Given this list of marker genes SPINT1, GJA1, RASSF7, EDIL3-DT, TNNT1, CDH3, CA9, DPP6, HAS1, ABI3BP, CARNS1, PALLD, CDH20, RALYL, KRT7, PROCR, MGAM, KLK11, INHBA, STK31, COL9A3, MGP, GSDME, FAHD2B, LSAMP, NETO1, LINC02613, MPP2, TGFB3, ZBTB7C, SMPD3, MYO5B, GSTM3, SFRP5, SMTNL2, DNAH7, COL8A2, CNGB3, MEIS1-AS3, BOC, EIF2AK3-DT, PTGFRN, OGN, CNTN3, PPM1E, NTNG1, LONRF2, FRMD6-AS2, NXNL2, BASP1-AS1, ALDH1A2, ITGB4, LRRIQ1, STON1-GTF2A1L, PDPN, PRX, ZBTB47, PHLDA3, PRDM6, ZNF649, PLAAT5, TFPI2, MUC16, PLCE1, TPBG, LINC00922, B4GALNT4, NBL1, SLC34A2, TTLL9, LAMA5 (laminin subunit alpha 5), LOX, CDH22, KRT18, SEMA3C, PIANP, FREM2, PAPPA, ADGRB2, HS6ST3, CASC20, LINC02643, LINC01996, SAMD11, COL11A1, COL12A1, GAS6, NXPH2, DLGAP2, CFAP221, GOLGA2P7, PLLP, C6orf132, GRIN2A, MYADM-AS2, MDGA1, TTC23L, EFNA4, CYP2W1, EGR1, IGSF9, ANKRD13B, GSG1L, LINC01508 (long intergenic non-protein coding RNA 1508), ARHGAP44, ARHGEF4, LINC01031, SULF1, TMSB15A, AMIGO1, CLIC3 (NCBI Gene Id 9022), CTNNA3, PTPRD, GFPT2, PHF21B (NCBI Gene Id 50609, PHD finger protein 21B), ODAD3, EPCIP, TEKT5, SPOCK1, TAF1A-AS1, KNDC1, FZD7, CYSTM1 (NCBI Gene Id 84418), ELN, MGAT4C, AXIN2, MMP24, RYR2, PDE7B, COL4A6, SMOC2, LRRN1, TENM3, PIWIL4-AS1, LINC01331, RTL8A, LRRTM3, PRR15-DT, LHX9, FLRT3, CFAP46, MIR100HG, CSDC2, HSPB2, ATF3, SLIT3, PTPRQ, OSR1, GALNT9, ELFN1, FBN3, IL17RE, PNMA8A, GRID2, GRIK2, SNAP91, SLC8A2, TLL1, CRB2, GNGT1, NEK5, LINC01140, PPL, MAD2L1BP, ACOXL, ARFGEF3, FGF18, TMEM132B, FOXC1, FNDC1, DISP1, RAB34, PDGFRL, GAS1, PARM1, COL21A1, ADAMTS9-AS1, LINC02381, ID4, VIT, RBFOX1, THSD4, EFEMP1, KRT19, EMP2, ARHGEF26, EPHB6, ALOX15, LURAP1L, RASSF8 (NCBI Gene Id 11228), ERBB4 (NCBI Gene Id 2066), PDLIM4, ADTRP, LGALS3, CAVIN1, CRIP1, CRACDL, ENTPD2, POF1B, FLNC, S100A10, HSPA1B, EZR, TMEM132C, LAMA3, CA11, FGF9, NKD1, MTMR7, LINC03051, DDR1, PDZK1IP1, HCFC1R1, CRYAB, NPNT, EPHA6, JPH4, WT1, WT1-AS, KLF2-DT, EVPL, SEMA3B, EPS8L1, POU6F2, CLIC5, NEBL, BNC2, GPC4, ASAH1-AS1, ITGB8, MAP3K21, SPEG, MEOX2, TRABD2B, CPAMD8, DPP4, NTRK3, RRAD, CFAP54, GADL1, KCNJ15, HTRA1, PNMA2, GRIA4, GABRB2, RGMA, CNGA4, MEDAG, NCR3LG1, SLPI, GRIN3A, PTPRF, PLA2G2A, PODXL (NCBI Gene Id 5420), C1QTNF1, CCDC80, AOX1, ADAMTS15, SILC1, PTPRT, COL4A3, ARL4D, CBX8, FAM110C, MYRF, SLITRK4, CYP4X1, LINC02024, UPK3B, LY6H, PTPRU, SEZ6L2, FXYD7, DSC3, CFTR, KLF5, SLC4A4 (solute carrier family 4 member 4), DCT, GXYLT2, VSTM2A, CTXN1, MSLN, TMEM132A, SPOCK2, SLC16A1, LAMC2, CFAP299, ABCG4 (ATP binding cassette subfamily G member 4), BNC1, CBLN2, CAVIN3, CGN, PEX5L (peroxisomal biogenesis factor 5 like), TGM1, C1QL1, NPHS1, SDR42E1 (short chain dehydrogenase/reductase family 42E, member 1), BRINP2, IGFBP5, PRR36, RSPO1, RHPN2, LMO4, CSPG5, KCTD8, COL8A1, ITGA3, CDON, HS3ST5, DNAI7, WNT2B, LRP2, here is a description of the gene set: species: Homo sapiens The gene expression program underlying the specification of human cell types is of fundamental interest. The study authors generated human cell atlases of gene expression and chromatin accessibility in fetal tissues. For gene expression, the study authors applied three-level combinatorial indexing to >110 samples representing 15 organs, ultimately profiling ~4 million single cells. The study authors leveraged the literature and other atlases to identify and annotate hundreds of cell types and subtypes, both within and across tissues. Our analyses focused on organ-specific specializations of broadly distributed cell types (such as blood, endothelial, and epithelial), sites of fetal erythropoiesis (which notably included the adrenal gland), and integration with mouse developmental atlases (such as conserved specification of blood cells). These data represent a rich resource for the exploration of in vivo human gene expression in diverse tissues and cell types. Human Gene Set: DESCARTES_FETAL_LIVER_MESOTHELIAL_CELLS Marker genes curated from the annotated cluster as represented in the Descartes Human Gene Expression During Development database. from publication Cao J, O'Day DR, Pliner HA, Kingsley PD, Deng M, Daza RM, Zager MA, Aldinger KA, Blecher-Gonen R, Zhang F, Spielmann M, Palis J, Doherty D, Steemers FJ, Glass IA, Trapnell C, Shendure J (PMID 33184181)